Given this list of marker genes ATP2B2 (NCBI Gene Id 491), SLC18A1, WSB1, GIPC2, FBL, KLHL20, ZNF81, MMP1, HTATSF1 (HIV-1 Tat specific factor 1), PIGK, PXN, MLXIP, CSF2, GPM6B, NCK2, ATP2B3, UBASH3A, DSTYK, DYNC1I2, TATDN2, AMBRA1, PACC1, BRCC3, PAX3, FZD5, GSC2 (NCBI Gene Id 2928), ABR, AGRN, PTPRN, EIF2D, SNX1, TRIM14, LILRB2, REC8, SSX2IP, CTNNA2 (catenin alpha 2), GRIK2, GABRA5, RABEP1, GFI1B, HOXD13, MCF2L-AS1 (NCBI Gene Id 80747), TAS2R10, BCAT1, ZNF771, FUT3, COPS2, SEMA5A, STIMATE, PDE12, NDUFS2, SOS2 (NCBI Gene Id 96829), SHOX2, ATN1, TOR3A, GSN, CD2BP2, MED12, LIPE, NFYB, ENPP4, NOX1, TRIM10, C9, FEZF2, PRPSAP1, OR7E36P, WDR45B, DENND2B, UBQLN4, GPR3, TEAD3, ATXN2L, APPL1, PLK4 (NCBI Gene Id 27119), NIPSNAP2, C11orf58, HMGCS1, RPL7, PAWR, ANKRA2, AK5, HDLBP, ALDOB, HEXA, DPY19L1P1, MYBBP1A (MYB binding protein 1a), DNM2, OGT, LAMC2, ATF7IP, NECTIN1, HMGN4, FYB1, MCHR1, MBNL1, BLVRA, MAP3K13, ITGB3, GOLGA2, MAPKAPK5-AS1, PCDH7, CHERP, SDHA, VEZT, PPP1R7, ARHGEF10, SH3PXD2A, SCGB1D1, TAF1B, KLRC4, TLE2, GALK2, MUSK, DMPK, CDK5RAP3, HNRNPA3P1, PALLD, EPHB1, KLK11, TAS2R14, LIMD2, ZNF214, ARHGAP26, IDUA, TSPAN4, MATN1, TRPM6, BCAN, GDF3, DCUN1D4, ATP4B, RAB36, DIXDC1, DLGAP1, TBC1D4 (TBC1 domain family member 4), ASPN, PRSS16, ABCB6, SEC23IP, GAD2, CST2, PDGFA, SCN1A, PCDHB1, MTNR1A (NCBI Gene Id 4543), SPSB3, SLC26A1, TRA2A, MDM4, CTIF, INTS14 (NCBI Gene Id 81556), FCHSD2, TRIM15, FZD1, SPTLC1, DCTN6, TNFRSF13B, C1orf54, PARP2, STXBP1, GGNBP2, ZNF177, USP53, ZNF174, LRAT, PEX12 (peroxisomal biogenesis factor 12), SHANK2, PROX1, STARD3, TNFRSF4, FDPS, AZGP1, MICU1, C1QB, CCN1, TIAL1, SH2B3, WNT4, GFOD2, CYP17A1, PPP1R11, PPIAL4A, OSBPL9, CYP3A5, SRSF6, TDRD1, WFDC1, CD86, ADAMTS13, DENND1C, NEUROG3, SRPX, CDH19, NETO2, OTUD3, MGAT5, SKP2, here is a description of the gene set: Genes up-regulated in neutrophils under hypoxia: EGLN3 knockout versus wildtype. Human Gene Set: GSE26023_PHD3_KO_VS_WT_NEUTROPHIL_HYPOXIA_UP from publication Walmsley SR, Chilvers ER, Thompson AA, Vaughan K, Marriott HM, Parker LC, Shaw G, Parmar S, Schneider M, Sabroe I, Dockrell DH, Milo M, Taylor CT, Johnson RS, Pugh CW, Ratcliffe PJ, Maxwell PH, Carmeliet P, Whyte MK (PMID 21317538) studied in species Homo sapiens Neutrophils were isolated form peripheral blood of wildtype and Phd3 null mice, cultured for 4 hours in hypoxia (3% O2) and micro array analysis performed The aim of the present study is to identify the mechanism by which phd3 is required for the hypoxia mediated survival of neutrophils